Given this list of marker genes UPP2, CMPK2, TYMP, NTHL1, DCTD, RRM2B, XDH, DCTPP1, MBD4, DTYMK, DGUOK, NT5C, NEIL1, NUDT16, SHMT1, ADK, NT5M, GDA, TDG, DNPH1 (2'-deoxynucleoside 5'-phosphate N-hydrolase 1), DCK, RRM2, NT5C2, NT5C1A, TBPL1, NUDT18, UPP1 (uridine phosphorylase 1), AK5, SMUG1, OGG1, DERA, RRM1, DUT, PNP, UNG, UPB1, NEIL2, SAMHD1 (NCBI Gene Id 25939), GUK1, NUDT15, DPYD, DPYS, ADA, TYMS, here is a description of the gene set: Human Gene Set: GOBP_DEOXYRIBONUCLEOTIDE_METABOLIC_PROCESS species: Homo sapiens The chemical reactions and pathways involving a deoxyribonucleotide, a compound consisting of deoxyribonucleoside (a base linked to a deoxyribose sugar) esterified with a phosphate group at either the 3' or 5'-hydroxyl group of the sugar.